Given this list of marker genes CBFB (core-binding factor subunit beta), CDKN2A, CCND1, TGFB1, HDAC4, KRAS, BRD2, EP300, RUNX3 (NCBI Gene Id 864), RUNX1, here is a description of the gene set: RUNX3 regulates p14-ARF Human Gene Set: REACTOME_RUNX3_REGULATES_P14_ARF studied in species Homo sapiens